Given this list of marker genes GTF2I, SOCS2, CTSH, TAX1BP1, APOC1, CPOX, IER3, NQO1, CTSL, ADAM10, NEFH, HSPA5, PIM1, AKR1C2, HBA1, UCP2, ICAM3, OSGIN1 (oxidative stress induced growth inhibitor 1), ID2 (NCBI Gene Id 3398), YES1, SLC27A2, DNAJB4, GYPA, MT2A, ETV5, FDXR, DDIT4, FTH1, HERPUD1, SLC43A3, NFYA, BIRC5, NPL, IER5, DHX9, INSIG1, CXCL2, NCOA1, MYB, ATF3, ANGPT1, HBZ, JUN, HSPA1B, KLF6, EGR1, NPRL3, MEF2C, FCGR2A, ATF5, NLRP1, SLC2A14, MCL1, PTP4A3, PTPN7, ITGB5, CAVIN1, CEBPG, RPP25, TXNRD1, MAFG, CEBPB, GP1BB, CXCL8, CREM, MOAP1, TXNIP, KLF1, FECH, AAK1, LMO2, GFI1B, AKR1C1, RTN4, here is a description of the gene set: Selected genes changed in K562 (immortalized erythroleukemia) cells induced by hemin treatment to express erythroid properties. from publication Addya S, Keller MA, Delgrosso K, Ponte CM, Vadigepalli R, Gonye GE, Surrey S (PMID 15252187) species: Homo sapiens Human Gene Set: ADDYA_ERYTHROID_DIFFERENTIATION_BY_HEMIN Understanding regulation of fetal and embryonic hemoglobin expression is critical, since their expression decreases clinical severity in sickle cell disease and beta-thalassemia. K562 cells, a human erythroleukemia cell line, can differentiate along erythroid or megakaryocytic lineages and serve as a model for regulation of fetal/embryonic globin expression. We used microarray expression profiling to characterize transcriptomes from K562 cells treated for various times with hemin, an inducer of erythroid commitment. Approximately genes were expressed irrespective of treatment. Comparative expression analysis (CEA) identified genes as differentially expressed; analysis by the self-organizing map (SOM) algorithm clustered genes into 8 distinct expression patterns, 322 of which were shared by both analyses. Differential expression of a subset of genes was validated by real-time RT-PCR. Analysis of 5'-flanking regions from differentially expressed genes by PAINT v3.0 software showed enrichment in specific transcription regulatory elements (TREs), some localizing to different expression clusters. This finding suggests coordinate regulation of cluster members by specific TREs. Finally, our findings provide new insights into rate-limiting steps in the appearance of heme-containing hemoglobin tetramers in these cells.